Given this list of marker genes Neil1, Alkbh1, Nthl1, Polb, Ogg1, Rps3, Neil2, Neil3, here is a description of the gene set: Mouse Gene Set: GOMF_CLASS_I_DNA_APURINIC_OR_APYRIMIDINIC_SITE_ENDONUCLEASE_ACTIVITY Catalysis of the cleavage of an AP site 3' of the baseless site by a beta-lyase mechanism, leaving an unsaturated aldehyde, termed a 3'-(4-hydroxy-5-phospho-2-pentenal) residue, and a 5'-phosphate. species: Mus musculus